The following is a description of a gene set: Human Gene Set: GOBP_FIBRINOLYSIS studied in species Homo sapiens A process that solubilizes fibrin in the bloodstream of a multicellular organism, chiefly by the proteolytic action of plasmin., and this is the list of marker genes: FGB, FGA, HRG, VTN, PLG, ANXA2, PLAT, PLAUR, PROS1, PLAU, FGG, KRT1, THBD, CPB2, APOH, SERPING1, SERPINE1, USF1, F12, FAP, KLKB1, F2, SERPINB2, THBS1, SERPINF2, F11, GP1BA